Given this list of marker genes NSMAF, TNNT1 (NCBI Gene Id 7138), ITGB1, GTF2E2, PLEKHB2, ACVRL1, ZNF106, FAS, TM6SF1, MRPS7, BTF3, PAXBP1, KCTD17, ZPBP, TNNI2 (troponin I2, fast skeletal type), SYNGR2, SYNE3, BAIAP2L1, UBE2L3, ACD, MFSD10, RCN3, BATF3, PDE3B, MKI67, NUP210, CYTIP (NCBI Gene Id 9595), TUBB2A, ETV6, BMP8A, RTCA (NCBI Gene Id 8634), RAPGEF5, PLEK, JUNB, TMED5, HINT1, ACBD6, CD68, ZNF600, KCNK6, COQ10B, TCTE1, CCDC6, DEPDC5, GLIPR1, FDX1, CCR5, GLIPR2, TLCD2, RRAGC, PDK3 (NCBI Gene Id 5165), CYBA, GOT1, NEU1, UQCRFS1, SLC35F5, ACKR2, DNM3, TGIF1, MANEA, SERHL2, CREG1, REL, MAGED1, ATP5F1C, RAB11A, KIAA1217, DENND11, AHCYL2 (NCBI Gene Id 23382), TFDP1, NR4A2, MAFF, GSTO1, ZBTB20, CXCR3, ATF3, FAM107B, TSPAN33, FAM167A, ANXA2, GPCPD1, ICA1, ATP6V1E1, MAN1C1, LGALSL, ZC3H12C, RPLP0, USE1, SKAP2, ARL13B, HK2, PITPNA, LMO7, UPB1, TUBB3, NUDT17, SNHG12, IPMK, MORN1, ERCC6L2, SRGN, BCL10, TPP2, PRDX6, CHP1, S100A6, TNFRSF1B, VILL, VRK2, DKKL1, CD86, PLEKHO1, AHCTF1, GPR34, NSD3, MNT, TTC7B, C19orf53, S1PR3, MZB1 (NCBI Gene Id 51237, marginal zone B and B1 cell specific protein), CACNA1S, PAK6, LCP2 (lymphocyte cytosolic protein 2), RGS10, EVI2A (NCBI Gene Id 2123), RPS10, NEIL1, ROPN1L, TEN1, TCP11L2, PI4K2A, AKAP1, AHR, GNG10, TMEM51, CENPA, TMEM135, RAB9A, ZNF703, IRF2BP2, HERPUD1, DDT, RNF138, SNX20 (sorting nexin 20), PKP4, HMGCR, NATD1, MPEG1, CAPNS1, IGBP1, HPD, ANAPC16, GSTT2, APRT, RELL2, CHST7, CEBPB, GPRC5A, SNX5, EBI3, AVPI1, LNX2, ZFAND5, SIRPA, FOXN2, RPSA, ATXN7L1, SLC36A4, ILDR1, MXD1, HSPA8, TNFRSF14, RAB43, GNG12, SLC15A3, SLC12A2, ATP6V0D1, ITPRIP, CYRIA, DHRS3, WBP1L, TEX30, CRIP1, LGALS1, TK1, ENKUR, ADAP1, SNAP29, ANKMY2, PYCARD, ZFAND3, TTC39B, SLC39A6, UNC119B, CASP4, EDEM1, UBAP2L, PSRC1, SMYD2, BATF, here is a description of the gene set: Human Gene Set: GSE411_UNSTIM_VS_100MIN_IL6_STIM_MACROPHAGE_UP Genes up-regulated in macrophages: untreated versus IL6 for 100min. species: Homo sapiens Effects of SOCS3 on the transcriptional response of bone marrow-derived macrophages to IL-6. Fetal liver cells from SOCS3+/+ or SOCS3-/- embryos were used to reconstitute recipient mice. Donor derived bone marrow from these mice was differentiated to macrophages. Macrophages were either unstimulated, or stimulated for 100 or 400 minutes with 10 ng/ml IL-6. from publication Lang R, Pauleau AL, Parganas E, Takahashi Y, Mages J, Ihle JN, Rutschman R, Murray PJ (PMID 12754506)